The following is a description of a gene set: Regulation of RAS by GAPs studied in species Mus musculus Mouse Gene Set: REACTOME_REGULATION_OF_RAS_BY_GAPS, and this is the list of marker genes: Psmb6, Psmc3, Kbtbd7, Psmd13, Psmc1, Rbx1, Rasa3, Psmb4, Psmd2, Psmc6, Psma3, Spred1, Psma2, Ubc, Psmb7, Psma5, Psmc2, Psmd3, Psmd7, Psma6 (proteasome subunit alpha 6), Cul3 (NCBI Gene Id 98674), Psma1, Psmd6 (NCBI Gene Id 66413), Psmd14, Psmb3, Uba52, Rasa1, Psma7, Rasal1, Psmb2, Syngap1, Psmd1, Nf1, Rasal2, Hras, Psmd11, Spred3, Ubb, Rasa4, Dab2ip, Rasal3, Psmd8, Kras, Adrm1, Spred2, Psma4, Rasa2, Psmc4, Uba52rt, Psmb1 (proteasome (prosome, macropain) subunit, beta type 1), Psmb5, Psmd12, Rps27a, Psmc5